Given this list of marker genes GRIN2B, GRIN1, GRIN2A, GPRIN3, PTCHD1, SHISA6, GRIN2C, SSH1, PDLIM4 (NCBI Gene Id 8572), PVALB, KCNQ3, CHRDL1, GRIN2D, here is a description of the gene set: Human Gene Set: GOBP_EXCITATORY_CHEMICAL_SYNAPTIC_TRANSMISSION Synaptic transmission that results in an excitatory postsynaptic potential. species: Homo sapiens